The following is a description of a gene set: Any process that modulates the frequency, rate or extent of removal of phosphate groups from a molecule. Mouse Gene Set: GOBP_REGULATION_OF_DEPHOSPHORYLATION studied in species Mus musculus, and this is the list of marker genes: Bmp2, Igbp1b, Ppargc1b, Mtmr4, Ccdc159, Mtmr3, Cdk5rap3, Chp2, Tmem132c, Ppp1r42, Mtmr2, Mtmr1, Epm2a, Npnt, Mef2c, Rock1 (NCBI Gene Id 68785), Iqgap1, Smg5, Src, Ppp1r17, Ripk3, Hpn, Bag4, Nron, Drd2, Mtmr9, Uri1 (NCBI Gene Id 97390), Plek, Inpp5k, Tmem225, Gpld1, Chp1, Ifng, Tnf, Adora1, Chrm5, Ppp2r3c, Igbp1